The following is a description of a gene set: Toe joint contracture Lack of full passive range of motion (restrictions in flexion, extension, or other movements) of a toe joint resulting from structural changes of non-bony tissues, such as muscles, tendons, ligaments, joint capsules and/or skin. Human Gene Set: HP_TOE_JOINT_CONTRACTURE studied in species Homo sapiens, and this is the list of marker genes: MMP2, DSP, FBN2 (fibrillin 2), MYH3, FHL1, GLI3, FGFR3, LIFR, PPP2R5D, IPO8, PIEZO2, CTDP1, TGFB3, FLNA, TBC1D2B, NOD2, BCOR, FBN1, PSMB8, JUP, NT5C2, SLC29A3, RYR3, CHRNG, PHF6, PRG4, ERCC1, ERLIN2, MYL11 (myosin light chain 11), AMER1, EIF5A, SCARF2, HSPG2, PIGN